Given this list of marker genes AGO1, TNRC6C, ANAPC4, UBE2S, ANAPC2, TNRC6A, MOV10, TNRC6B, CDC23, CDC16, ANAPC15, CEBPB, FZR1, ANAPC11, AGO3, LEF1 (NCBI Gene Id 51176), UBE2C, UBE2D1, CDC26, NFKB1, UBE2E1, TP53, ANAPC5, CTNNB1, AGO4 (NCBI Gene Id 54791), CDKN2A, VENTX, ANAPC10, ANAPC7, ANAPC16, RELA, CCND1, CDC27, EHMT1, TCF7L2, IL6, MIR24-2, EHMT2, ANAPC1, MIR24-1, CSF1R, here is a description of the gene set: Human Gene Set: REACTOME_TRANSCRIPTIONAL_REGULATION_BY_VENTX Transcriptional Regulation by VENTX species: Homo sapiens